Given this list of marker genes Gm2415, Golga4, Ttc21a, Vill, Glb1, Eomes, 4933411E02Rik, Gm25059, Gm9385, Gadl1, Zcwpw2, D730003K21Rik, Scn10a, Epm2aip1, Tgfbr2, 4930545L08Rik, Slc22a13b, Plcd1, Gm36745, D330037F02Rik, Dclk3, Gm26614, Osbpl10, Scn5a, Gm10608, Ccr4, C130032M10Rik, Mir26a-1, Clasp2 (CLIP associating protein 2), Trim71, Gm4665, Tmppe (transmembrane protein with metallophosphoesterase domain), Gpd1l, 4930520O04Rik, Dync1li1, Cmtm8, Gorasp1, Ubp1 (NCBI Gene Id 22221), Acaa1b, Mir467h, Wdr48, Stmn1-rs1, Azi2, Acvr2b, Acaa1a, Gm17396, Ctdspl, Platr11, Gm10157 (NCBI Gene Id 102639922), Gm23889, Gm4657, Slc22a14, Myd88, Gm18935, Gm36367, Gm31410, Gm33460, Rps27rt, 4921528I07Rik, Gm29825, Mlh1, Scn11a, AU023762, Exog, Gm7183, 4933432G23Rik, Lrrfip2, Gm36485, Dlec1, Mir128-2, Gm16142, Crtap, Xylb, Cmc1, Gm9888, Itga9, Arpp21, Gm4668, Gm9487, Oxsr1, Gm22479, Stt3b, Slc22a13, Pdcd6ip, Cmtm7, Gm36251, Rbms3, 2900079G21Rik, Trank1, Bcl2a1c (B cell leukemia/lymphoma 2 related protein A1c), Fbxl2, Cnot10, Gm5921, Stac, Gm7780, Gm17399, Cmtm6, Gm2449, Gm18489, 2310075C17Rik, Susd5, here is a description of the gene set: Mouse Gene Set: chr9F3 species: Mus musculus